The following is a description of a gene set: Human Gene Set: KEGG_MEDICUS_PATHOGEN_KSHV_MIR1_2_TO_ANTIGEN_PROCESSING_AND_PRESENTATION_BY_MHC_CLASS_I_MOLECULES studied in species Homo sapiens Pathway Definition from KEGG: (MIR1,MIR2) -| MHCI KSHV MIR1/2 to antigen processing and presentation by MHC class I molecules. Pathway ID: N00184. Pathway type: Pathogen. Pathway class: nt06229 MHC presentation., and this is the list of marker genes: HLA-C, HLA-B, HLA-G, HLA-E, HLA-F, HLA-A